Given this list of marker genes ABCD3, DGUOK, HCST, DYNLL1, SIGLEC1, PRDX1, FH, JPT2, DDIAS, PROK1, SSR3, KRCC1, TRAPPC12, TIMM17B, LMAN2, PRDX4, ACADM, SRCAP, MZB1, PDIA4 (protein disulfide isomerase family A member 4), ARHGAP19, PPP1R21, DNAAF10, LRIF1, ASXL2, AFTPH, ATP1A1-AS1, DECR1, TMCO1, NDUFA8, ORMDL2, FUNDC1, WASHC3, THOC2, SHQ1, SPOP, KCNJ15, NUDT13, SLAMF6 (SLAM family member 6), VBP1, NDUFB6, AARS1, NEK7, ARMC1, OSTC, CFAP298, PSMB2, EEA1, TIMM8B, PLAC9, POU5F1B (POU class 5 homeobox 1B), PPP3CB (protein phosphatase 3 catalytic subunit beta), HMOX2, BFAR, HM13, PRIM1, PITPNB, EIF2S1, RRM2, GATD3 (glutamine amidotransferase class 1 domain containing 3), LMAN2L, XRCC5, NDUFAB1, IGLV3-19, TUBB, TMEM260 (transmembrane protein 260), BORCS8, MRPL51, MCCC2, SERPING1, APOBEC3B, METTL5, GNPDA1, MID1, FBH1, MEA1, AIDA, SUCLG1, RPS16, UQCRQ, STT3A, ARL2, LINC01304, ZNF623, HOMER1, PSMD1, CCT2, NDUFC1, C2orf74, HDLBP, APEH, MRPL36, MAP3K7, GJB4, ORM1, FAM120B, HSD17B4, MGAT2, ROBO2, CCT7, MRPL18, ATP5PF, NAA20, NDUFB10, AVIL, C1QB, PSMD4, RPS6KA1, PCNA, DPY30, TTF1, CDCA7 (cell division cycle associated 7), GLT8D1, MTIF2, DRG1 (NCBI Gene Id 4733), CYB5B, COPB2, GGH, PLPBP, ATP8B1, PSMA4, ENO1, CDH10, HSP90B1, PAQR8, MTIF3 (NCBI Gene Id 219402), ZNF146, UBXN8, RETN, PMS1, METTL8, NDUFB4, SLC26A2, MTCH2, MRPS14, RNF5, RPS27L, ARV1, FASTKD1, ALG8, TASOR, EIF3J, MTF2, RPA3, SAMM50, TRG-AS1, SDHAF3, HDAC2, SCOC, SEC61A1, SIGLEC9, DNAJC7, UQCR10, GOLGA5, EAF2, SSB, NUDT5, SP140, NNT, FKBP2, RACK1, MITD1, TSNAX, OMA1, ECH1, ZWINT, KLHL31, HAX1, PSME3IP1, AURKAIP1, MRPS6 (NCBI Gene Id 64968), IFNA7, TNNT1, DCK, TMPO, TADA3, STAMBP, CEACAM8, PSMD14, EFTUD2, HTATSF1P2, CREB3 (cAMP responsive element binding protein 3), TRAPPC8, MRPL24, SLC44A1, PPID, SDF2L1, EXOC5, GPSM3, SPCS1, HDHD2, AP4E1, DDB1, ZBTB8OS, ING4, PPP1R7, LYRM4-AS1, GNPAT, here is a description of the gene set: species: Homo sapiens Human Gene Set: GSE29617_CTRL_VS_TIV_FLU_VACCINE_PBMC_2008_DN Systems vaccinology has emerged as an interdisciplinary field that combines systems wide measurements and network and predictive modeling applied to vaccinology. Here we used the systems vaccinology approach to study the molecular mechanisms underlying th Genes down-regulated in comparison of peripheral blood mononuclear cells (PBMC) from TIV influenza vaccinee before vaccination versus that after the vaccination. from publication Nakaya HI, Wrammert J, Lee EK, Racioppi L, Marie-Kunze S, Haining WN, Means AR, Kasturi SP, Khan N, Li GM, McCausland M, Kanchan V, Kokko KE, Li S, Elbein R, Mehta AK, Aderem A, Subbarao K, Ahmed R, Pulendran B (PMID 21743478)